The following is a description of a gene set: Mouse Gene Set: MIR_7079_5P from publication Chen Y, Wang X (PMID 31504780) studied in species Mus musculus Genes predicted to be targets of miRBase v22 microRNA mmu_miR_7079_5p in miRDB v6.0 with MirTarget v4 prediction scores > 80 (high confidence targets)., and this is the list of marker genes: Tagln, Serpinb10, Tal2 (NCBI Gene Id 21350), Zhx3, Swap70, Polr1f, Reep3 (NCBI Gene Id 28193), Samd4b, Ubn1, Vtcn1, Casp14, Sae1, Dlg2, Cyp26b1, Csnk1g1, Galnt6, Cnksr2, Pak5, Rac1, Rfxap, Sestd1, Txlna, Tef, Etv5, Irgm2, Nkain2, Col8a2, Kremen1, Asb8, Zfp821, Sema5b, Sdc3, Gm4847, Flot1, Usp14, Iqsec1, Mkx, Fzd4, Tspan7, Nptx1, Atf7ip, Slc8a1, Nck2, Vamp2, Rgs14, Znrf1, Kcnv2, Vipr2, Pramel21, Nectin1, Cxcl16, Gpr25, Neu2, Slc25a21, Jade2, Larp1, Chrna3 (NCBI Gene Id 235388), Zfp764l1, Plekhm3, 5031439G07Rik, Unc5b, Abraxas2, Zfp568